Given this list of marker genes CAPN15, POU2F1, EPHA7, LTBP1, ZNRF3, KIAA1210, SEC22B, SOX11, NDST3, TOB2, EOMES, ACSM2B, AP1AR, ZNF780B, ZNF506, VAPB (NCBI Gene Id 9217), CFAP97, TACC2, CSPG4, EHF, CCR2, MAP2K4, UPRT, DTX4 (deltex E3 ubiquitin ligase 4), EDN1, BARX2, TMOD2, TRHR, DDAH1, TMEM242 (NCBI Gene Id 729515), PRAME, CREB5, AGO4, NAA16, KPNA1, ASIC1, SRP54, NBN, ZNF135, PMEPA1, EPC1, LRP12, ROBO2, FNDC9, KLF12, KAT5, QKI (QKI, KH domain containing RNA binding), PHF23, BMP2K (NCBI Gene Id 55589), TMOD3, FAM117B, EFEMP2, DUSP6, TOX2, LYZ, PLCB1, CPD, ADCY3, RPL28, DKK2, SAYSD1, RCC1, XCL1, ZNF600, CDKL5, HNRNPUL2, RFX5, RECK, DDX3X, NUP88, HS1BP3, SEPTIN6, ATG9A, RGCC, TOP1, RAB11A, TIE1, TRAF2, HOXA10, INTS8, KRT80 (keratin 80), ICE2, SLC22A5, ESRP1, MS4A6A, MAP2K6 (NCBI Gene Id 5608), RIPK1, EDEM1, STK38L, MAP4K5, NUDT13, INO80D, KCNQ3, PTGER3, ZNF71, PTHLH, S1PR1, MAP1A, GPR161, TAF5, SPATA13, BTN3A1, GATAD2A, TMEM121B, ADRA1A, TRIQK, FSD1L, RP2, SPEG, TAF1C (TATA-box binding protein associated factor, RNA polymerase I subunit C), DCC, APLN, VBP1, HMGA2, ADCY1, NCAN, KLHL42, ZNF384, SMG7 (NCBI Gene Id 9887), NTRK2, FRMD5, TGFB3, NUAK1, RAP2A, ENPP3, SNX31 (sorting nexin 31), here is a description of the gene set: Genes predicted to be targets of miRBase v22 microRNA hsa-miR-4287 in miRDB v6.0 with MirTarget v4 prediction scores > 80 (high confidence targets). species: Homo sapiens Human Gene Set: MIR4287 from publication Chen Y, Wang X (PMID 31504780)